The following is a description of a gene set: species: Homo sapiens This array analysis is to study developmental time course of the regulation of target messages’ expression during culture of murine neutrophils versus miR-223 null neutrophils. Culture media was SILAC-IMDM for MS analysis. Human Gene Set: GSE12003_MIR223_KO_VS_WT_BM_PROGENITOR_4D_CULTURE_DN from publication Baek D, Villén J, Shin C, Camargo FD, Gygi SP, Bartel DP (PMID 18668037) Genes down-regulated in 4 day cultures of bone marrow progenitors: wildtype versus MIR223 knockout., and this is the list of marker genes: SLC19A1, KIF2C, PROM2, ACRV1, HLCS, GRIN2B, OSCAR, GABRB1, TRAPPC3, AICDA, BAALC, CACNG4 (NCBI Gene Id 84745), S100A5, ARL2, CLDN14, RUVBL2, FGFR4, CHL1, GEMIN6, DNER, NEFL, XRN1, MAPK13, CACNG5, TLCD2, MPI, KRT18, EPB41L3, NOP16 (NCBI Gene Id 51641), GABRA2, KRT23, FOSL2, ADAT1, SDC2, CES3, IKZF2, ADH1C, RASL11B, PTF1A, PCDHAC1, ADAP2 (ArfGAP with dual PH domains 2), APBA2, DTD2, NOS1, TMEM260 (NCBI Gene Id 54916), NANS, LPAR1, ATP6V1C2, PDAP1, SULT2B1 (NCBI Gene Id 6820), DRD2, RWDD3, EBF2, TRPC4, PPP1R3C, MTURN, NKX6-1, ZIM3, LTC4S, ZDHHC2, SPEF1, FGF18, ZP2, MMD2, CKM, TNFRSF19, ABHD18, ZMAT5, PSMC1, PGM1, FCRL1, ITSN1, COL17A1, MFSD4B, CFD, FAM167B, KHDRBS3, SLC22A9, TTC16, SFN, P3H4, P2RY12, ERN1, CPS1, ALOX15, COL18A1, C1QC, PTPN18, CHCHD5, SVEP1, CHRNA4, SLC16A2, OR7C1, POMP, SLC8A2, KHDRBS2, PDE4A, TMEM41A, CCDC22, SERPING1, KIF1A, ZP1, PCDH18, MELTF, MED4 (NCBI Gene Id 51757), COL5A3, VSTM2A, RBPJ, IL9R, CLPB, HSPB2, IAPP, XPO5, PLIN2, RXRA, PCDHA12, PROX1, SLC25A24, NOP58, KCNMB4 (potassium calcium-activated channel subfamily M regulatory beta subunit 4), PGAM2, HAVCR1, RERG, MARK1, PPP2CB, TMED8, TSSK1B, ZFR2, LUM, FUT4, EIF4B, CD200, CPB2, DKKL1, SRPX, FBXO32, APOF, SLC20A2, PRKG2, SAAL1, DGAT2, SRPK3, HES7, ACD, ADAM12, MLLT3, PRSS21, LIN37, LYRM2, MERTK, IL36A (interleukin 36 alpha), CORIN, KIF18A, PXMP4, MYH4, ALPL, SRRT, NME6, UNC5C, PSMD8, RABGAP1L, CD86, MAST1, CHIC1, FLJ13224, CPA1, CNTRL, MSMB, BAG2 (NCBI Gene Id 9532), IL15RA, SPHK2, HOXA3, CCL20, TTI2, PDE6B, MARCKS, ANKRD22, IRX4, SLC16A3, PKHD1, OMP, PHB2, PLAC1, TNFAIP3, TM4SF20, TMEM150B, HAPLN1, PDE6G, MPV17L, MPP2, ESR2, MED9, ACP2, CLEC14A, CCDC65, DBN1 (drebrin 1), IL1F10, PALLD, PKD2L2, HOXB9